Given this list of marker genes B3GNT3, C4BPB, RTKN, PRMT6, MIPOL1, PPARGC1A, FOXA3, CLDN4, MUC13, MMP7, FBLIM1, FGG, KRT18, DSP, FOXA1, GPRC5B, GPR160, CHODL-AS1, AGR2, CCDC68, KRT6A (keratin 6A), CYP3A5, NEBL, ALPL, ELF3, GSTM1, PGAP4, FAM83D, HOOK1, ANXA9, MYO6 (NCBI Gene Id 4646), RAB25, AIFM2, LIPG, NUP210, GGT1, SLC38A1, TMEM98, EPCAM, FBP1, TSKU, KRT19, ST3GAL5, ZKSCAN3, FAT1, CA11 (carbonic anhydrase 11), LRRC37A4P, CUX2, CD24, LGALS3BP, SLC8A3, GDA, GRTP1, CDH3, LTF, TP53I3, LYZ, MUC1, TRPS1, H19, NCF1C, GALNT3, GINS1, HPGD (15-hydroxyprostaglandin dehydrogenase), SPON1, CXCL14 (NCBI Gene Id 9547), CCL15, RHOBTB1, OCLN, CYP26A1, CAMKV, SLC5A4, CDH10, KRT14, ZBED3, ANK3, GAL, CDKN2A, GSTM4, SEC22C, GATA3, MST1R, NEK3, LAD1, CDCA5, PRSS2, ADIRF, CEACAM6, SERPINB6, GPRC5D, E2F8, SLC25A18, MYO10 (NCBI Gene Id 4651), CD4, PPL, CTSE, LILRB4, NGFR, FZD3, C4orf19, PXMP4, AJUBA, AKR1C1, UGT1A1, GSTM2, RERG, PSG5, KRT17, PLA2G2A, IGFBP2, MLPH, PLBD1, SDC1, DLK1, KRT6B, TSC22D3, LGALS4, XDH, TSPAN8, MAL2, SELENBP1, PRSS23, NHERF1, EPHA2, AZGP1, VWA1, C4B, MTARC1, TSSK1B, CRABP2, VAV3, NBL1, APOA1 (NCBI Gene Id 335), UBXN6, PRSS8, LRRC61, F2RL1, SCNN1A (sodium channel epithelial 1 subunit alpha), REG1B (regenerating family member 1 beta), HYAL1, PRR15L, SSH3, LRRC4, MYL9 (myosin light chain 9), LAMP5 (lysosomal associated membrane protein family member 5), TAGLN, PCDHB5, ZFP36L2, WWC1, DNAJA4, KRT8, KRT5, PTPRF, CDKN1A (NCBI Gene Id 1026), TACSTD2, KIAA0040, S100P, FOLR1 (NCBI Gene Id 2348), IGFBP1, IL1RN, GPX3, FMOD, PELI1, CLU, MAP7, SLPI, SH2D4A, RNF43, BACE2, ECM2, CDH1, SYT17, DZANK1, TAGLN3, GPC1, DNMT3B, OLFM2 (NCBI Gene Id 93145), REEP6, CAVIN1, LAMC2, PTGFRN (NCBI Gene Id 5738), TNFRSF10A, LMTK3 (NCBI Gene Id 114783), FXYD3, EGLN3, GPRC5A, SPINT2, CNKSR1, ARHGEF5, TENM1, EPS8L2, BMP4, CLDN7 (NCBI Gene Id 1366), KRT7, CDH17, ZFP41, GRB7, WLS, CALML3, H2BC21, KLF8 (KLF transcription factor 8), STMN1, GPX2, STXBP6, HLA-DRB5, DDX11L2, SORBS1, F11R, CYB5A, DEFA3, HSPB8 (heat shock protein family B (small) member 8), WFDC2, PPP1R14C, here is a description of the gene set: Human Gene Set: MODULE_342 Genes in the cancer module 342. studied in species Homo sapiens